Given this list of marker genes NDST1, RRBP1, ID2, PIP4K2A, EMX2, LY6K, GNS, ABHD5, SUCO, PDCD4 (NCBI Gene Id 27250), UBE2E2, DSE, DCLRE1C, LILRB4, RASGEF1B, TSGA13, HCK, ITPR2, CD9, KCNK5, PLXND1, CD81, DRAM2, LY6S, PTPN14, ATP6V1G2 (NCBI Gene Id 534), PRDM1, RUNDC3B, TNFRSF18, TLR7, PKIB, MATK, CD86, FCRL5, PRKDC, MYCBP2, BCAR3 (NCBI Gene Id 8412), IL9R, TMTC4 (transmembrane O-mannosyltransferase targeting cadherins 4), CD300LF (NCBI Gene Id 146722), CACNA1E, RXFP1 (relaxin family peptide receptor 1), LAIR1, CYP39A1, CREBL2, NEDD4, FUCA1, TBL1XR1, BLNK, GRK3, MARCKS, SLC29A3, OBI1, TERB1, PTPN18, TAF1D, DTX1, BZW2, COPG2, DLL3 (NCBI Gene Id 10683), UBE2R2, GM2A, FUCA2, ARHGAP24, TRPM2, CYFIP1, CCR1, PDE4D, LYNX1, S1PR1, NIBAN3, CARMIL1, ALPL, CD36, MTNR1A, PLD4, PTK2, ITGAL, MYL4, ERO1A, FFAR2, SLC38A9, DPH5 (NCBI Gene Id 51611), SORBS2, PER3, ACKR2, FMNL3, SLC39A6, CIBAR1, GRAMD1B, UXS1, RUFY3, PKD1, ATXN1, PLBD1 (NCBI Gene Id 79887), HMGN3 (NCBI Gene Id 9324), INPP5F, NEBL, PDE8A, RBM47, TMEM131, PTPRJ, MS4A14, CD274, SRGAP3, HSPA5, PSAP, DUSP16, CYBB, CSF2RB, MCOLN3, HERC3, TRAF1, TUBG2, NRP2 (neuropilin 2), WDR11, CD180, CDC42BPB, RILPL2, PPL, ABR, BID, CD38, NAB1, ARHGEF12, TSPAN15, RNFT2, CARS2, PLAC8, CR2, TLR3 (NCBI Gene Id 7098), PDLIM2, LPCAT2, GPR156, RPS20, GRN, CDH17, EDEM1, AS3MT, ELL3, MYC, SLC9A9, ACBD4, HES5, MICAL3, ZC3H12C, RPS9, PLXNC1, SEMA7A, TMEM26, PLEKHA1, ZDHHC14, ASNS, ASB2, RGS10, TYROBP, PSMD14, PLA2G7, ACKR3, TBC1D9, UTRN, IKZF1, MS4A1, BCAP29, ZKSCAN1 (NCBI Gene Id 7698), GOLIM4, FBXO9, MYOF (NCBI Gene Id 26509), SH3KBP1, TCF4, PGC, BLK, TRIM32, PIK3R4, here is a description of the gene set: from publication Kasturi SP, Skountzou I, Albrecht RA, Koutsonanos D, Hua T, Nakaya HI, Ravindran R, Stewart S, Alam M, Kwissa M, Villinger F, Murthy N, Steel J, Jacob J, Hogan RJ, García-Sastre A, Compans R, Pulendran B (PMID 21350488) studied in species Homo sapiens Many successful vaccines induce persistent antibody responses that can last a lifetime. The mechanisms by which they do so remain unclear, but emerging evidence suggests that activate dendritic cells (DCs) via Toll-like receptors (TLRs). For example, the yellow fever vaccine YF-17D, one of the most successful empiric vaccines ever developed, activates DCs via multiple TLRs to stimulate pro-inflammatory cytokines. Triggering specific combinations of TLRs in DCs can induce synergistic production of cytokines, which results in enhanced T cell responses, but its impact on antibody responses remain unknown. Learning the critical parameters of innate immunity that programs such antibody responses remains a major challenge in vaccinology. We demonstrated that immunization of mice with synthetic nanoparticles containing antigens plus Toll-like receptor (TLR) ligands 4 (MPL) + 7 (R837) induces synergistic increases in antigen-specific, neutralizing antibodies compared to immunization with a single TLR ligand. To determine whether there was any early programming of B cells, we isolated isotype switched, TCRbeta-CD11b-CD19+IgD-IgG+ B cells by FACS at 7 days post immunization with nanoparticles containing various adjuvants plus OVA, and performed microarray analyses to assess their molecular signatures. Genes up-regulated in B lymphocytes after immunization with: monophosphoryl lipid A versus imiquimod. Human Gene Set: GSE25677_MPL_VS_R848_STIM_BCELL_UP